The following is a description of a gene set: Mouse Gene Set: GOBP_CD4_POSITIVE_ALPHA_BETA_T_CELL_CYTOKINE_PRODUCTION Any process that contributes to cytokine production by a CD4-positive, alpha-beta T cell. studied in species Mus musculus, and this is the list of marker genes: Il18rap, Il31ra, Gba1, Arid5a, Nlrp3, Il4, Gata3, Il25, Il1r1, Il18, Xcl1, Slamf1, Stard7, Arg1, Il1b, Il12b, Rsad2, Tbx21, Il18r1, Crlf2, Dennd1b, Ifnb1, Prkcz, Cd81, Il6, Fosl2, Il12a